The following is a description of a gene set: Human Gene Set: RUBENSTEIN_SKELETAL_MUSCLE_MYELOID_CELLS from publication Rubenstein AB, Smith GR, Raue U, Begue G, Minchev K, Ruf-Zamojski F, Nair VD, Wang X, Zhou L, Zaslavsky E, Trappe TA, Trappe S, Sealfon SC (PMID 31937892) species: Homo sapiens, and this is the list of marker genes: LY96, MOB1A, OSTF1, TMSB10, SNX3, VMP1, JAML, RPL15, RNASE6, NDUFB1, RPL21, FOS, PLEK, PLP2, CDKN1A, SMCO4 (single-pass membrane protein with coiled-coil domains 4), RAP1A, ID2, UQCRH, HLA-DMA, EIF3L, REEP5, CRIP1, CSF2RA, KLF4, FCGR1A, MRPL52, PLSCR1, CASP4, CYBA, CDC42, NDUFB5, PTPRC, RGS10, EEF1B2, TXNDC12, FGL2, RPL32, NR4A1, CD14, IL1B, OST4, WDR74 (WD repeat domain 74), CALHM6, COX4I1, COTL1, JUND, CD74, RPS2 (ribosomal protein S2), ACTB, RPS4X, MCL1, FCER1G, CCNI, RPLP1, CMTM6, NDUFB3, BLOC1S1, COX7C, CYRIA, EIF4E2, CD44, EIF3F, RPL11, EIF4EBP1, SARAF, BTG2 (NCBI Gene Id 7832), DNAJB1, GABARAP, C5AR1, SMDT1, CYBB (cytochrome b-245 beta chain), HSBP1, GAPDH, DUSP2, FCGR3A, CDC42SE1 (NCBI Gene Id 56882), SPI1, RNF130, ARPC3, GLRX, CTSB, C1orf162, RPL17, HLA-DRA, SAMHD1, CKLF, SERP1, RAB5IF, RHOG, CST3, PTP4A2, TMEM167A, IL10RA, STX11, MT-CO1, FTH1, CD53, PRR13, SEC11A, RPL38, SSB, RPL19, TYROBP, SAT1, SERF2, ATP5PB, RPL28, IFNGR2, DYNLT1, SLC25A6, RGS2, POLE4, NPC2, RPL37, HERPUD1, RPS12, LST1, SUPT4H1, NOP10, ZNF706, CD55, CREG1, LRRFIP1, TBCA, PCBP2, TIMP1, NAP1L1, PPP1R18, SSR3, ATP6V0D1, S100A4, EIF3K, MS4A6A, CXCL8, NEDD8, ATP6V1F, TSPO, AP2S1, AP1S2, PLAUR, TBXAS1, LAMTOR2, RPS23, CTSS, SLC25A5, FTL, NAAA, ENY2, SERPINB1, ATP5MC2, UBA52, EEF1A1, RPL23A, HLA-DPA1, SELENOH, LAMTOR1, METTL9, ITGB2 (integrin subunit beta 2), NFKBIA, RPL4, CLEC2B, HSPA1A, LAMTOR4, CPVL, VAMP8, NAMPT, ABRACL, APOBEC3A, CTSH, CD48, MNDA, CARD16, PPT1, ATP5F1E, S100A9, RPL7, HSD17B11, ARRB2, TMSB4X, PFN1, HLA-DRB1 (NCBI Gene Id 730415), RPL22L1, M6PR, ZFAS1, RPL30, NFKBIZ, TNFSF13B, LYZ, COX7A2, S100A8 (S100 calcium binding protein A8), RGS18, EIF1 (NCBI Gene Id 1963), VPS29, UQCRFS1, AIF1, CITED2, SFT2D1, PGLS, LAPTM5, ALDOA, RPS4Y1, HNMT, SSR2, ATP5MG, ATP6V0E1, HCK, SH3BGRL3, SMAP2, MACROH2A1, SNHG8, PFDN5, CEBPB, FCN1, RPS28, FCGRT, PPP1CA, RPS3A, RPS9, RPS13, CASP1, RPL27 (ribosomal protein L27), FYB1, BID, GCA, CLEC7A, CD83, COMMD6, RPL39, RPL26, LSP1, SUB1, EIF3E, NUP214, RPS19, GPX1, CD37, CTSZ, TYMP, S100A11, GSTP1, LCP1, FXYD5, PGK1, BLOC1S2, IER3, RPL41, GMFG, ARPC5, MS4A7, SERPINA1, ATP1B3, RPS16, RPL36A, FPR1, LYST, PYCARD, PABPC1, GLIPR2, EMP3, PSAP, S100A6, IGSF6, ATP6V0B, HLA-DPB1, RPS24, ZFP36, PPP1R15A, PRELID1, S100A12, SRGN, NICOL1, RPLP2, SOD2, OAZ1, RPL6, RNASET2, EIF4A1, HIGD2A, CAPZA1, ASAH1, ENSA, PLAC8 (NCBI Gene Id 95621), EFHD2, TPM3, UBE2D1, VMA21, RPS29, CCL3, TMEM176B, CD68, LTA4H (NCBI Gene Id 4048), TSC22D3, FOSB, UBE2D3, ATP5MJ, CSTA, TKT, COX5A, ACTR2, GDI2, LY86, ARHGDIB, YBX1, NACA, LIMD2, RPL34, CAPZB, CFP, TALDO1, ARPC1B, CSTB, RPS21, PLBD1, IFI30, PDCL3, H3-3A, CYRIB, ARPC2, LSM6, HCST, DUSP1, HCLS1, RPL36AL, GLIPR1, RPL23, CORO1A, ACTR3, CD52, LILRA5, CFL1, SPG21, NR4A2, RPS14, JUNB, SLC31A2, PILRA, STMP1, GPSM3, MPEG1, RPS7, CYCS (cytochrome c, somatic), STXBP2, PRDX3, UCP2, VCAN, BCL2A1